Given this list of marker genes Gm48551, Dohh, Eif5a, Eif5a2, Dhps (deoxyhypusine synthase), here is a description of the gene set: Hypusine synthesis from eIF5A-lysine Mouse Gene Set: REACTOME_HYPUSINE_SYNTHESIS_FROM_EIF5A_LYSINE studied in species Mus musculus